Given this list of marker genes Exosc4, Exosc5, Dis3, Xrn1, Exosc9, Exosc7, Dxo, Exosc10, Exosc6, Zcchc7, Exosc8, here is a description of the gene set: A process that identifies and degrades defective or aberrant mRNAs within the nucleus. studied in species Mus musculus Mouse Gene Set: GOBP_NUCLEAR_MRNA_SURVEILLANCE